Given this list of marker genes Camkk1, Camkk2, Calm1, here is a description of the gene set: This event has been computationally inferred from an event that has been demonstrated in another species.<p>The inference is based on the homology mapping from PANTHER. Briefly, reactions for which all involved PhysicalEntities (in input, output and catalyst) have a mapped orthologue/paralogue (for complexes at least 75% of components must have a mapping) are inferred to the other species. electronically inferred by orthology from the curated human pathway Reactome Pathway: CREB1 phosphorylation through the activation of CaMKII/CaMKK/CaMKIV cascasde part of: Post NMDA receptor activation events species: Mus musculus